Given this list of marker genes PTPRO, CYP4A11, SERPINF2, MRGPRD, F2R, SUCNR1, CYP11B2, CORO2B, AGTR2 (angiotensin II receptor type 2), PCSK5, COMT, ADORA1, GAS6, CYBA, GJA5, EDNRB, AGT, PDGFB, HSD11B2, F2RL1, MAS1, RHOA, REN, OR51E2, EMP2, TTR, AGTR1, CYP4F12, CYP4F2, here is a description of the gene set: species: Homo sapiens Human Gene Set: GOBP_RENAL_SYSTEM_PROCESS_INVOLVED_IN_REGULATION_OF_SYSTEMIC_ARTERIAL_BLOOD_PRESSURE Renal process that modulates the force with which blood travels through the circulatory system. The process is controlled by a balance of processes that increase pressure and decrease pressure.